Given this list of marker genes ZNF749, PABPC5, PCDH10 (NCBI Gene Id 57575), THYN1, MAP2K6, LRRC19, ACSL6, AFF4, PRKAA2, SNX31, MARCHF3, CHP1, MPV17, IL25, GPR63, AFF2, GPR180, RAB3C, GSTA4, ARHGEF28, CD44, MAP3K20, FRK, REEP3, RAB23, USP3, TWIST1, PCGF5, CRYBG3, NR4A3, DYNC2LI1, NR2C1, CNTN6, CIDEB (NCBI Gene Id 27141), TMEM169, ANTXR2, ATN1, PTBP3, MORC3, ZNF714, AGK, MBD4, TMEM230, FCGBP, CNTNAP2, GAN, ZMYND8, CNOT8, CASZ1, DGKH, ITCH, PLCB4, CDC14A, PKIA, PPFIBP1, BAZ2B, CD274, FGD6, GCDH, TROAP, BECN1, ZNF664, ETV1, ZNF273, ARMC10, ANKRD50, FAM210A, SPRY1, C8orf33, THAP10, TNS3, NPAT, TTC39B, ABCC4, C11orf54, DNM1, EXOSC8, CHIC1, KCNJ4, TMEM47, LIN7C, MIPOL1, CARF, ZNF267, POLR3B, EPRS1, RASAL2, PLPP3, DPYD, PTPRK, EYA4, LIPA, ZBTB41, C4orf33, PF4, CNNM4, FRMD5, SYP, ZNF793, CCDC112, UBE2V2, GABRA4, AKR1C2, HNF1B, ANO1, TMT1A, ITM2B, SLC6A7, ANGPT1, TRAF3, ZIC1, PFKM, TFAP2B, USP15, CDKL5, NPR2 (natriuretic peptide receptor 2), BTNL3, TPBG, HMGN3, TRAPPC11, COL13A1, ZDHHC5, ELAVL2, TGM2, LILRA1, CDH6, GFPT1, SULT1E1, CAP2, TANK (TRAF family member associated NFKB activator), DRD1 (NCBI Gene Id 1812), ATXN3, STYK1, KRTAP1-1, KCNV1, FGD4, ZNF770, CA8, CHMP4B, TOPBP1, ZCCHC24, ADGRL4, SYNPO2, PTPN4, CELF2, SLC39A12, BMP2, RAD17, OSBPL3, SPACDR, SLC24A2, TOB1, NLGN4Y, SMDT1 (NCBI Gene Id 91689), SATB1, SULT1C3, CCDC136, PRKD3 (NCBI Gene Id 23683), ENPEP, RBL1, DIXDC1, ADCY6, DENND4A, VCPIP1, KIAA2013, SLC6A8, SLC39A10, CXorf66 (chromosome X open reading frame 66), FAM241A, ATG2B, NTS, PAIP2B, L3HYPDH, JAG1, IGF1, PPP1R3G, RNF38, SMAD9, PLEKHM3, RSRC2, ELOVL7, PANK1, TMEM130, UNC13C, BTBD1, SMARCAD1, SYT1, MYADM, CDKL4, BRIX1, DOCK4, ACBD3, ZEB2, TNIK, PSMG2, PERP, TNFSF13B, SULT2A1, CDH11, DARS1, BLZF1, QKI, MICU1, KRTAP2-1, KLHL4, LDOC1, PHF20L1, NAA30, KRT28, RSBN1, CNR1, ANKIB1, RIOX2, ZCCHC18, C7orf25, THAP12, PRIM2, KRT31, SNAP25, PRRG1, HOOK3, MIB1, TMEM175, COCH (NCBI Gene Id 23718), ZNF681, KIF16B, CNTN1, CMSS1, ADRB3, PDE6C, PCLO, CPXCR1, here is a description of the gene set: Genes predicted to be targets of miRBase v22 microRNA hsa-miR-3145-3p in miRDB v6.0 with MirTarget v4 prediction scores > 80 (high confidence targets). studied in species Homo sapiens Human Gene Set: MIR3145_3P from publication Chen Y, Wang X (PMID 31504780)